The following is a description of a gene set: electronically inferred by orthology from the curated human pathway Reactome Pathway: Golgi Associated Vesicle Biogenesis part of: trans-Golgi Network Vesicle Budding This event has been computationally inferred from an event that has been demonstrated in another species.<p>The inference is based on the homology mapping from PANTHER. Briefly, reactions for which all involved PhysicalEntities (in input, output and catalyst) have a mapped orthologue/paralogue (for complexes at least 75% of components must have a mapping) are inferred to the other species. studied in species Mus musculus, and this is the list of marker genes: Pum1, Rab5c, Fth1, Bloc1s1, Pik3c2a, Ocrl, Dnm2, Snx9, Ap1m1, Ap1b1, Ap1s3, Dtnbp1, Arf1, Gak, Necap1, Yipf6, Cpd, Igf2r, Vamp2, Snx2, Dnajc6, Ap3s1, Bloc1s3, Picalm, Vamp8, Hip1r, Ap1s1, Tpd52l1